The following is a description of a gene set: All-trans retinoic acid (RA) induces transforming growth factor beta (TGF-beta)-dependent autocrine growth of mouse embryonic fibroblasts (MEFs). We have used chromatin immunoprecipitation to map 354 RA receptor (RAR) binding loci in MEFs, most of which were similarly occupied by the RAR alpha and RAR gamma receptors. Only a subset of the genes associated with these loci are regulated by RA, among which are several critical components of the TGF-beta pathway. We also show RAR binding to a novel series of target genes involved in cell cycle regulation, transformation, and metastasis, suggesting new pathways by which RA may regulate proliferation and cancer. Few of the RAR binding loci contained consensus direct-repeat (DR)-type elements. The majority comprised either degenerate DRs or no identifiable DRs but anomalously spaced half sites. Furthermore, we identify 462 RAR target loci in embryonic stem (ES) cells and show that their occupancy is cell type specific. Our results also show that differences in the chromatin landscape regulate the accessibility of a subset of more than 700 identified loci to RARs, thus modulating the repertoire of target genes that can be regulated and the biological effects of RA. from publication Delacroix L, Moutier E, Altobelli G, Legras S, Poch O, Choukrallah MA, Bertin I, Jost B, Davidson I (PMID 19884340) studied in species Mus musculus Genes bound by RARG and down-regulated by tretinoin (all-trans retinoic acid, ATRA) in MEF cells (embryonic fibroblast). Mouse Gene Set: DELACROIX_RAR_TARGETS_DN, and this is the list of marker genes: Tpm2, Fgfr2, Kitl, Ckb, Fign, Lsp1, Gas2, Gjb5, Palmd, Ogn, Fubp1, Nrp1, Zfp469, Ube2c, Mrgprf, Clnk, Emp1 (epithelial membrane protein 1), Plscr2, Sntb2, Echdc3, H1f2 (NCBI Gene Id 68317), Timp3, Fstl1, Ccnd1, Aqp5, Ctbp2